Given this list of marker genes AHCY, GNMT, MAT1A, AHCYL1, DNMT3B, MAT2B, DNMT3A, MAT2A, DNMT1, AHCYL2, here is a description of the gene set: species: Homo sapiens Human Gene Set: KEGG_MEDICUS_REFERENCE_METHIONINE_DEGRADATION Pathway Definition from KEGG: Met -- MAT >> (GNMT,DNMT) >> AHCY -> Hcy+Adenosine Methionine degradation. Pathway ID: N01607. Pathway type: Reference. Pathway class: nt06030 Methionine metabolism.